Given this list of marker genes CRMP1, TYROBP (NCBI Gene Id 7305), DPYSL5, ROCK2, LIMK1, SEMA4A, ARHGEF12, RHOB, RRAS, PLXNA3, TLN1, SEMA7A, CDK5R1, PLXNA1, CD72, PLXNB1, MYL6, RND1, DPYSL3, FARP2, ITGB1, PLXNC1, PLXNA2, PIP5K1C, SEMA6A, MYL12B, TREM2, CFL1, LIMK2, SEMA6D, DPYSL2, PAK2, SEMA3E, PLXND1, FYN, PLXNB3, NRP1, MYH14, ARHGEF11, DPYSL4, ARHGAP35, FES, RAC1, PTPRC, MYH10, MYH9, SEMA3A, MYH11, ROCK1, CDK5, RHOA, SEMA5A, SEMA4D, HSP90AA1, PLXNA4, HSP90AB1, MYL9, ITGA1, GSK3B, MET, ERBB2, PAK1, RHOC, PAK3, here is a description of the gene set: Semaphorins are a large family of cell surface and secreted guidance molecules divided into eight classes on the basis of their structures. They all have an N-terminal conserved sema domain. Semaphorins signal through multimeric receptor complexes that include other proteins such as plexins and neuropilins. studied in species Homo sapiens part of: Axon guidance Reactome Pathway: Semaphorin interactions